The following is a description of a gene set: The formation of mesodermal clusters that are arranged segmentally along the anterior posterior axis of an embryo. Mouse Gene Set: GOBP_SOMITOGENESIS species: Mus musculus, and this is the list of marker genes: Sfrp2, Aldh1a2, Ppp2r3a, Otx2, Foxf1, Plxna2, Tbx6, Tbx18, Ttn, Meox1, Sfrp1, Psen2, Smad4, Ror2, Lhx1, Hes7, Atm, Cobl, Dmrt2, Sema3c, Mesp1 (NCBI Gene Id 17292), Wnt5a, Foxa2, Pax3, Rbpj, Nrarp, Dll3, Foxb1, Xrcc2, Pax1, Kat2a, Foxc1, Ep300, Kdm6a, Ripply2, T, Nckap1, Epb41l5, Bmpr1a, Zeb2, Mib1, Ripply1, Tcf15, Lef1, Notch1, Ifitm1, Gdf3, Taf10, Poglut1, Crb2, Nle1, Lrp6, Smad3, Dkk1, Med12 (NCBI Gene Id 59024), Nkx3-1, Prkdc, Palb2, Tmed2, Foxc2, Dll1, Abi1, Wnt3a, Axin2, Lfng, Myf5, Pofut1, Psen1, Msgn1, Trp53, Meox2, Pcdh8, Mesp2, Cdx2, Myf6, Cdx1 (NCBI Gene Id 12590), Tcap